Given this list of marker genes Slc20a1, Hoxd11, Add1, Hnrnpa2b1, Tex16, Lancl2, Ccdc25, Plod2, Cpeb3, Tafa1, Ganab, Eif3j2, Zdhhc9, Rbm47, Chst11, Mmp16, Avl9, Creb3l2, Sox4, Lztfl1, Tmt1a, Gcm1, Fxr1, Zfp935, Purg, Ppp1r9a, Pclo, Vcan, Ranbp3l, Tmem196, Adam34 (NCBI Gene Id 252866), Tmprss11d, Fam168a, Elavl4, Fam124a, Runx3, Pigr, Nkx6-3, Cep68, 2610008E11Rik, Dph5, Cutc, Igfn1, Syt16, Amotl1, Ccdc116 (NCBI Gene Id 76872), Amd2, Tyr, Naa12, Cdh6, Cct2, Lbh, Rbpms2, Nol4, Cdk14, Sec14l3, Trappc3l, Gm6878, Rbm41, Arhgef37, Tango6, Ephb1, Atp2b2, Amot, Paqr4, Atp6v1g1, Pou2f1, Rnf20 (ring finger protein 20), Il19, Tal1, Mef2c, Jkamp, Lrch2, Ankle2, Ttc23, Awat1, Dlx3, Fut9, Fasl, Med1, Rnf169, Cnpy3, Pkn2, Kmt2a, Cul4b, Ctla4, Psmd1, Plxna4, Zfp273, Epha5, Mtfmt, Cfap68, P2rx7, Zfp811, Dbndd2, Cplx2, Dcaf7, 0610030E20Rik, Dram2, Hltf, Ncam1, Phactr1, Adamdec1, Dnase2a, Tnfrsf23, Pdik1l, Krt25, Slc9a9, Jakmip2, Rab3c, Ercc6, Erbin (NCBI Gene Id 72261), Megf11, Snx3, Dcc, Akap11, Emp2, Bcor, Bpifa6, Satb2, Zfp85, Erg, Nrxn1, Ppp2cb, Ten1, Magea2, Mmrn2, Cox17, Psen2, Wac, Otor, AI987944, AW146154, Prx, Il17a, Cngb3, Prrg4, Phf3, Brinp1, Aak1, Ifi205, Sec61b, Zfp930, Thsd7a, Chodl (chondrolectin), Rbbp5, Tfec, Ralgapb, Vav3, Krt71, Kctd4, Ceacam13, Dele1 (DAP3 binding cell death enhancer 1), Neto1, Plekha8, Fbxo45 (NCBI Gene Id 75407), Gcdh, Eda, Commd2, Pgbd5, Nus1, Parp8, Themis, Cavin2, Ifi211, Cftr, Zfp60, Hmgn3, Nhlh2, Btbd9, Pah, Cdc73, Slc4a4, Mrpl19, Slc23a1, Axin2, Timp3, Fgf20, Car8, Megf9, Cacna2d1, Ccdc190, Tmt1a2, Prdm1, Sgtb, Strap, Sec22a, Pcdh17, Kcna1, Sgms2, Baalc (NCBI Gene Id 72779), Mdga2, here is a description of the gene set: studied in species Mus musculus from publication Chen Y, Wang X (PMID 31504780) Genes predicted to be targets of miRBase v22 microRNA mmu_miR_1903 in miRDB v6.0 with MirTarget v4 prediction scores > 80 (high confidence targets). Mouse Gene Set: MIR_1903